Given this list of marker genes LRRFIP1, FGFRL1, CREB3, CD36, KBTBD11, MLST8, here is a description of the gene set: studied in species Homo sapiens Genes predicted to be targets of miRBase v22 microRNA hsa-miR-4520-5p in miRDB v6.0 with MirTarget v4 prediction scores > 80 (high confidence targets). Human Gene Set: MIR4520_5P from publication Chen Y, Wang X (PMID 31504780)